Given this list of marker genes NECAP1, MINDY1, CTNS, RPP38, SERBP1, DNAJC13, SLC41A2, SNORD101, MARS2, NIPAL1, PSMD9, R3HDM1, GCNT3, TTI1, LETM1, KCTD9, ZCCHC8, TECR, RPS6, LIMA1, MOCS3, MYO1D, AHCYL2, ZNF292, OSGEPL1, RHOBTB3, SEPTIN7, SMIM14-DT, HOXA7 (NCBI Gene Id 3204), SDHD, LAMP1, EXD2, MTERF4, RGS5, NDUFB6, ZNF846, MED8, CLNS1A, SAE1, SERGEF, OXCT1, AP2S1, N6AMT1, ZC3H12D, MTRF1L, PHTF2, UQCRB, TSG101, SRRM2, TMEM260, CEP44, ZNF74, MRNIP, METTL3, RPUSD2, NDE1, RNU7-1, MTUS1-DT, PRKAG1, GDAP1, PRP4K, SHROOM3, ALOXE3, BNIP2, HOXA-AS3, LARP6, KIF20A, HMBS, SIAH1, RPUSD3, AGR2, LYSMD3, RBKS, BTNL8, JADE2, DMXL2 (Dmx like 2), PELO-AS1, SBNO1-AS1, ZNF213, EXTL3, MYLK-AS1, SMG7, ZNF436, CLDN12, ATF7IP (activating transcription factor 7 interacting protein), SH3BP5L, TRMT6, SURF6 (surfeit 6), ILF2, PPARD, MIR194-2HG, NDUFB9 (NADH:ubiquinone oxidoreductase subunit B9), DNAJC21, EIF5, NUDT12, NCOA3, SEMA4F, ABCF2, USPL1, SLAIN2, ZNF460, INTS2, EFCAB14, AKT2, GPR146, ERCC2, ZNF225-AS1 (ZNF225 and ZNF224 antisense RNA 1), LTO1 (ABCE maturation factor), RSRC2, EXD1, CFAP96, ANP32E, KAT5, ZNF426, RPAP3, SLC36A1, VARS2, AQR, SNHG20, GOT1, ZFP91-CNTF, TYW1B, MIR320A, MTERF1, ALDH4A1, VRK3, MRRF, EPC1-AS2, ZNF407, SRSF4, TM2D3, CAMKMT, TARDBP, RRH, RTCA, RPL34-DT, WBP11, H3C10, DMAC2, PIGL, INTS12, DNAJB1, IGF2BP3, ACTR1A, NSA2, RAB30-DT, TPBG, HRG-AS1, FAM120AOS, EMG1, GPATCH2, PIDD1, MBD4, ELP2, C19orf53 (NCBI Gene Id 28974), TIMM9, SHPK, PWWP2A, NDUFC2-KCTD14, MGST3, EPM2AIP1, SART3, MIR3646, RLIM, LINC02777, BRD2, GPR19, DPAGT1, DDX10, SYF2, UXS1, FKBP2, SMARCAD1-DT, VPS13B-DT, SETD5, SUMF2, RNU2-2P, MIR3678 (microRNA 3678), TFG, SPATS2L, TMEM109-DT, USF3, TMEM11-DT, ATP13A1, HOXC-AS2 (NCBI Gene Id 100874364), LSM6, REXO5, MLH1, HSPE1, KATNBL1, TTC32-DT, ITFG2-AS1, ERCC6L2, HADHB, OSR2, GAB1, IFNLR1, COPZ1 (COPI coat complex subunit zeta 1), LINC02038, IWS1, RNF111, CTDSPL2, CD164, ZNF628, RPL34, LINC00963, FGFBP3, BCKDHB, PPIA, LIN37, XPR1, H4C3, CC2D2B, CDK2AP2, ARRDC3, SLC39A8 (solute carrier family 39 member 8), CCNI, VPS13B, OXA1L-DT, SLC39A11, EBLN3P, TRIM23, RAVER1, ZNF407-AS1, RN7SK, ZNF426-DT, SLC4A1AP, ZC3H11A, RAB3D, PPP4R1-AS1, STXBP3, SLCO3A1, AP3S1, WASHC2C, MAP4K3, HERPUD1, STK25, FAM21EP, NKAPD1, CFAP298-TCP10L, PIM1, ERBB2, XRCC1, MGME1 (mitochondrial genome maintenance exonuclease 1), RBBP4, THAP2, EDN1, STAG1, ATG101, RBM48, MAP3K4, ATP11B, EDEM2, EFHD1, ITGA7 (NCBI Gene Id 81988), ERCC5, GNL1, EMP1, RPGRIP1L, TRAF3IP2, UTP23, CLASP1-AS1, RABIF, RNF126, LINC01852, RNU6-563P, VPS8, ZNF815P, CASP2 (NCBI Gene Id 835), JPT1, NDUFC2, WBP4, KIAA0586, ARHGAP5, GTF3C2, RBM39, IQCD, ACADM, C1orf21, GABARAP, CKAP2, PRPF31, USP34 (ubiquitin specific peptidase 34), MFSD1, EPRS1, RSL1D1, NCOR2, CHCHD2P6, ZNF213-AS1, GBA1LP, CCDC137, SNX24, RNU6-112P, SGO1-AS1 (NCBI Gene Id 100874028), EIF3H (NCBI Gene Id 8667), MEPCE, MIR4512, TMEM222, SREK1, UMPS, LSG1, SLCO5A1, CPSF2, ERAP2, ZNF830, RPRD1B, SMARCAD1, APBB2, DCDC1, FAM53C, VTRNA1-1, SPRY4 (sprouty RTK signaling antagonist 4), CRYZ (crystallin zeta), TIMELESS, AUTS2, BTBD3, SLC20A1, TOX4, TAF12-DT (TAF12 divergent transcript), DDB1, DNAJC24, RSL1D1-DT, FAM156A, ZNF473, MAP7, PPP2CA-DT, PRR11, ZBTB7C, LAPTM4A-DT, CAAP1, RPL27A, CDC45, BOD1, MORF4L2-AS1, RRP12, SLC22A5 (solute carrier family 22 member 5), ITPRID2, PRR15, IDH3B, ERI2, VPS50, RPL21, UFC1, G6PC3, PRPF39-DT, ZNF3, SOBP, COMMD10, GALNT16-AS1, DNAJC18, TARS1-DT, KIAA0319, WWP2, CBX5, DPP9, RETREG2, FBXL19, POGLUT1, RNASEK, CNIH1, TTC14-DT, THBS3-AS1, HDAC8, GLRX, ITM2B, RGS17P1, MYOF, ODR4, SNORA7A (NCBI Gene Id 619563), SEC14L1, NSUN2, SYTL2, HOXA10, ZNF394, USP28, NUP107-DT, SRD5A1, MTPAP, IFTAP, MEIS1, EPCAM-DT, RBM4, STK11IP, NPTN, UBE2Q1, RPS23, CCDC12, RPS27, C21orf91, NDFIP1, RNU6-2, ZNF770, KLHDC10, PSMC3IP, HOXA3, NARF, RNY3, TPCN1, ZNF687 (zinc finger protein 687), SSR3, CHAC1 (NCBI Gene Id 79094), SEMA3C, ILF3, AGL, LRRC66, SCP2, PIK3R1, QRSL1 (NCBI Gene Id 80136), PPP6R3, H4C12, SPC25, MCFD2, WARS1, EID2B, MARF1, PIPOX, ENC1, SNAPC5, TMEM259, RPS29P16, NFE2L1-DT, SLC38A7, HSPD1 (heat shock protein family D (Hsp60) member 1), SP8, MSL2, IDH3B-DT (IDH3B divergent transcript), PDSS1, RPP14, LRRC31, TEN1, RAB18, SUB1, SEC11C, FMNL3, WDR77, MRPL46, RPS27L, SMG7-AS1, SKP1, SHC4, FERMT1, BRD8, WASHC2A, MVB12A, UBLCP1 (NCBI Gene Id 134510), GARS1-DT, DDX60L, ENSG00000236098, C7orf50, TTI2, PHLPP2, DGUOK, TTC14, PPP2R1B, PSMG3 (proteasome assembly chaperone 3), CDK13, ERCC1, GLO1 (glyoxalase I), WDSUB1, RAD51-AS1, ZDHHC14, ANKRD13C-DT, C11orf58, CNOT6, SRP54, CLN3, ZNF181, ACOX1, NCLN, ITSN1, GGT7, ANG, CRYBG1 (crystallin beta-gamma domain containing 1), ERV3-1, PARK7 (NCBI Gene Id 113880), NHLRC3, EMC9, CCAR2, TNKS, TMEM232, RAB5IF, CEBPZ, EFCAB6, NDUFA6-DT, OXLD1, TCERG1, DNAJC8, PDK2, FAM21FP, RTN3, PUS10, OGDH, TMEM138, DYNLRB1, CLPB, MATCAP2, BCAS2, PPFIA3, PTPRO, ACHE, NEK7, ZSCAN2, SLC7A11, MALAT1, ATP10B, MICOS10-NBL1, SNRNP27, SMIM14, PREPL, MIX23, AP2M1, GTF2A2, RALA, MRPS35-DT, IPO4, NDUFAF7, PLOD3, RABGAP1L, TMEM229B, ATP5PO, TARBP1, HMGB3P22, GLTC1, NWD1, RBBP8, ZNF77, HOXB6, LINC01411 (NCBI Gene Id 101928176), RAD9A, ARHGAP27, PPM1D, LYPLAL1, HACD2, SLC11A2, PCYT1A, PRPF19-DT, SNRPA1, INO80B, SELENOW, DOLK, SZT2, RHEBL1, PRRC2C, OMA1, TTC19, MEF2C, WASF2, CLCN7, ITPR1-DT, THUMPD3, KNTC1, SMIM10L1, PHACTR4, ICA1-AS1, GAS5, MMADHC, FHDC1 (FH2 domain containing 1), ILF3-DT, MPC1, H4C4, DCTN6-DT, SSR2, ZFP36L2, PTPRH, SCAMP2, NPM1, TAF12, AAGAB, EFCAB6-DT, UBE4B (ubiquitination factor E4B), ZFC3H1, TBL3, CKAP2-DT, ADNP, PRLR, TRAF3IP2-AS1, ANXA4, AAK1, SNX1, RAD51AP1, NAGLU, EBNA1BP2, ZNF767P, MIR4521, ZNF12, ZNF117, POLR1G, SLC25A12 (NCBI Gene Id 8604), COQ8B, ETFA, RPS19, ENSG00000257184, NDUFS7, RPL41, KDM4C, MUTYH, PAK1IP1, NDC80, THRAP3, SRSF7, RBM27, RBCK1, TRA2A (transformer 2 alpha homolog), PSMC2, STAT6, ZFP37, EXPH5, SMPD3, PRDX3, RAB11FIP3 (RAB11 family interacting protein 3), RPL30, ATAD2B, FAM162A, CCZ1P1, ZBED5, C6orf52, TBCB, TMEM234 (NCBI Gene Id 56152), NDUFA6, ING1, TIMM8B, VPS4B, RN7SL3, FUZ, HERC4, BCO1, SBDSP1, GALNT5, ENSG00000267882, NUP107, PRKCSH, ERCC6L2-AS1, BANF1, MAEA, JKAMP, ACTR3B, DPM1, STAU1, GTPBP6, ITFG2, NFE2L3, PROSER1, FCHO2, HSD17B2, OPA1, HNRNPC, CHD8, IFT70B, HOMER1, RNF32-DT, RPPH1, PSMB7, TBC1D15, HMGN1 (NCBI Gene Id 3150), MICOS10, HERC6, MRPL24, UNK, IER5L-AS1, ZSCAN16, HNRNPA2B1, TMEM109, H3C1, TBC1D10A, RPL7L1, CNPPD1, CFAP69, PTGS2, SPNS1, KCTD16, HECTD1, LINC02068, HNRNPA1, MIRLET7IHG (NCBI Gene Id 120766144), TRPM7, UNC45A, SPICE1, TOMM7, CCDC163, TMEM205, MIIP, ERH, REV3L, ARPIN, KIZ, CD320, MRPL48 (NCBI Gene Id 51642), VASH2, SERP1, TPR, PIK3CA, CEBPZOS, MYBBP1A, WDR5B, FARSB, THADA, MEF2C-AS2, PGAP3, PEF1, INO80E (NCBI Gene Id 283899), ESRP2, BMI1, ASNSD1, RMI1, TBCCD1, SLC20A1-DT, SYMPK (symplekin scaffold protein), PCAT7, RNF10, GRPEL1, MIR7111, B4GALNT1, EPS8, ROCK2, POLR2K, MDM4, HIRIP3, C4orf19, SUPT6H, STARD4, G3BP1, ZFP91, OXA1L, ZNF25, PALS1, PRKCI, GBA1, FXR1, TMEM266, SUN1, MYG1, SH3RF2, FIRRM, UFSP2, HCG14, MCCC2, CRTC3-AS1, DNLZ, LINC-PINT, KITLG, HIBADH, NR6A1, CDON, ERCC8, RPAP3-DT, MCU, SLC18B1, MORF4L2, RACK1P1, PHF12, ZC3HAV1, TRMT10C, RPL24, SPR, RRAGC-DT, ZMAT2, PITX2, DMTF1, RRS1, RNASEK-C17orf49, ZNHIT1, EML6, ABHD14B, MOSPD3, MIR1915HG, C19orf44, KIF22 (kinesin family member 22), TSHZ1, RNU2-17P, BMS1 (BMS1 ribosome biogenesis factor), CACYBP, FAM174A, HOXB3, BRCA2, MOGAT3, ZBTB5, SPRED2, FOXA3, ISOC2, EIF2AK2, LAPTM4A, PABPN1, WDR62, WDR24, KBTBD6-DT, CBY1 (NCBI Gene Id 25776), DHX35, RBM7, SLCO5A1-AS1, ATP7B, CSNK1A1, IFRD2, ODAD3, RMDN1 (regulator of microtubule dynamics 1), IKBIP, EFCAB11, AXDND1, CIAO2A, TMC1, PPP4R3B, ACP6, UBALD2, POM121, MOCS2, H2BC5, LARS1, POLR2I, CCDC18-AS1, SERPINI1, NOL6, MOB4, TMEM183A, LIN54, RAB7A, ITGB6, HTD2, ASB8, GSPT1, PDCD2L, RANGAP1, NSMCE3, BPNT2, NUDCD1, NMT1, H2AJ, NUMA1, TNKS1BP1, NEK10, NARF-AS2, FKTN, CFAP57, SETDB2, CAP1, SLC6A6, PDCD10, TRAPPC6B, FRAT1, DEPDC4, XPOT, BCS1L, NCBP1, GDPGP1, HSPA5, UGT1A6, SORBS1, ARMH3, EIF2B1, COMMD9, PIGBOS1, PKIB, PIGS, CWC22, DSG1-AS1 (DSG1 antisense RNA 1), SUGP2 (SURP and G-patch domain containing 2), ENSG00000272008, LINC01126, CNNM2, GALNS, RAD17, ITPR1 (NCBI Gene Id 619543), GABARAPL1, ENSG00000232995, RPLP2, SNHG4, LYRM1, UXT-AS1, ZAR1L, C12orf60, HIGD2A, EID1, IFT46, PTPA, TOE1, CCDC150, TMEM39A, SESN1, DMAC2L, YIPF3, SULT1D1P, ZNF142, RIGI, P4HA1, TEN1-CDK3, YWHAZ, LIMD1-AS1, CAB39L, MAGOH, DCAKD, SLC39A9, TFDP2, TFAM, MTCH1, RAB2B, TNKS2, BRCA1, DENND2D, TMEM219, SREBF2-AS1, CSNK2A1, UXT, BTBD8, FBXW11, BTRC, RAB27A, SPINK5, THRB-AS1, COQ10B, CMC1, NBN, LINC00923, RACGAP1, ZBED5-AS1, TTC17, H2BC6, EHHADH, CNTRL, BAZ2B, CRAT, AP5Z1, DNMT1, POLR1C (RNA polymerase I and III subunit C), FNDC3A, LIN52, ZNF24, ORMDL3, YJU2B, MRPS18A, ARSK, B3GAT3, C11orf71 (NCBI Gene Id 54494), CLNK, ARMC6, ZBED6, INO80D (INO80 complex subunit D), LINC00649, EP300, MLLT3, HNRNPK, ANKRD17, SNX5, CUL5, KARS1, GABPA (GA binding protein transcription factor subunit alpha), ARRDC3-AS1, TDP1, GARS1, SGO1, HSD11B1L, CCT6B, PDXDC1, BCL6, NFE2L1, HOXA-AS2, PRR3, RNU6-502P, ZNF225, RPIA, GPR160, FAM227A, FAM200A, RACK1, SKAP2, NDUFB1, CANX, NOD1, DYNC2H1, DOHH, GRPEL2 (NCBI Gene Id 134266), MIR1915, RPS17, IFT122, MFSD8, SDF2, TRAPPC2L (NCBI Gene Id 51693), RAB28, LINC03015, TNRC18, SIRT4, BRD10, FOS, CLRN3, ALKBH8, NUP188, VPS33A, UBE2L6, R3HDM2-DT, AKAP9, GEMIN2, ACAD10, ORC5, FER, ARPIN-AP3S2, CCDC127, GDF9, SOX6, APC, CCNL1, ISL2, MCM8, CACNB2, HES1, SRGAP3, ELP3, MED4, LPXN, LMO7, SKIC3, PPP1R12B, CEP85, BLOC1S1, C10orf143, DCUN1D3, LUC7L2, MIA3, SPIN1, CYP4F12, RAB29, EIF3A, LSM2, LINC00471, RNU6-841P, SYAP1, PSME2P3, EZH1, SULT6B1, TMBIM6, NAA38, CDC27, HPS1, PJA2 (praja ring finger ubiquitin ligase 2), P4HB, PCCA, WNK1, RSBN1L, ALDH6A1, XPO1, KBTBD6, PPP1R13L, CCDC125, SUCLG1, CCDC159, LINC02168, DCTN4, ATG12, TXNDC9, SHLD3 (NCBI Gene Id 112441434), RIMKLB, KLHL12, RTN4IP1, SERF2, LSM8, PANK4, SLC39A6, HDAC5, MMUT, MCC, NEMF (NCBI Gene Id 9147), ARL5A, FAM13A, ISLR2, SELENOOLP, PTPRE, WDR25, TACC2, MAP3K5, INO80 (NCBI Gene Id 84156), SLC25A46, MIS12, ATP6AP1L, FAN1, MRPS15, SRRM2-AS1, ORAI1, NHSL1, WDR5B-DT, HNRNPH3, ZSWIM7, QTRT1, RBIS (ribosomal biogenesis factor), SLCO2B1, PEF1-AS1, RND3, NCAPG2, TRIM69, PIGB, FBXO33, HNRNPA3, MIA2, SPATA17, AASDH, PHB2, MARCHF8, LINC00511, TMSB10, ATXN2L, HSPA9, CEP57L1, ISOC1, SOS1, DAB1, NDUFS8, DERL2, PAPSS1, CDS2, C12orf57, SRP19, CREBRF, ZNF684, BTN3A3, REG4, RBM47, WDR74 (WD repeat domain 74), DPYSL2, RAB30, LINC03014, AGAP2-AS1, ATR, MNAT1, CCNJL, NDUFAF6, CALCOCO1, PVR, ARHGEF37, DLEU2, TRPC4AP, NUF2 (NUF2 component of NDC80 kinetochore complex), MRPS22, SMARCAL1, DDX46, CENPQ, INO80B-WBP1, BCL2L14, TARS1, MALINC1 (mitosis associated long intergenic non-coding RNA 1), PRR7, EIF1, MRPS11, HSP90AB1 (heat shock protein 90 alpha family class B member 1), CUL2, MRPL43, CHD2, BTBD1, ZW10, TKFC, USP3-AS1, IMMP1LP1, SDHC, NCK2, RPL26, TWNK, BAG6, ATAD2, RPL32, NFATC2IP, SNX10, DMTF1-AS1, ZNF436-AS1, KBTBD2, CA13, TMCO4, SNCAIP, PISD, MCOLN1, TBL1XR1, NFXL1 (NCBI Gene Id 246220), CALM2, TFPT, PFDN4, RFX3, TTC32, RPL30P11, MMACHC, RALBP1, SCARNA16, TEC (NCBI Gene Id 7006), HMGB1, TMCO6, SNORD95, RNF216, NRBF2, TATDN1, SUPT7L, H3-3B, EHD4, SLC52A3, H4C16, LAMA3, TERF2IP, CBLB, OSGEPL1-AS1, RBM25, CCNB1, CAST, SYVN1, ANKRD13C, RPS12, COA6, TMBIM1, MEF2A, CEP63, ERCC4, MIR4757, SOX2-OT, MATR3, RPL36, ABCB6, SPRYD4, FTO (NCBI Gene Id 79068), TMEM11, PPP2CA, CFAP298, TK2, USP22, NUB1, EHF, ST3GAL2, ALDH7A1, ZRANB3, SRSF5, UQCR11, EIF3K, NFKBIZ, GET4, AGPS, ADCY3, EEF1AKMT1, CHP1, C2orf88, NR2F2, VAPA, BCL2L13, H2BC13, SRPK1, SRP54-AS1 (NCBI Gene Id 102723366), MAPKAP1, PIH1D2, SMAD5, USP16, PPP1R12A, ENSG00000275740, FAM114A2, MGST2, NEDD9, CREBZF, ZNF446, PLAC8, DHX35-DT, PRR7-AS1, ATP5PF, OTUD4, RAD51, LINC02615, UFD1, MTOR, ZFAND1, MAP4K1, RRS1-DT, SRSF10, COX6B1, ZNF343, ACSS2, DCTN2, PRPF19, TBC1D7, YJU2, TGIF1, CDCA2, GRB2, BLM, POLR3D, GFM1, AHCTF1, EIF3I, HOTTIP, RXFP4, ENSG00000275765, CALR3, TRIM37, CYB5D1, FKBP3, UQCRQ, SUPT4H1, LINC02971 (NCBI Gene Id 124904558), ZNF774, TRIQK, HSPA8, MOCS2-DT, NOSIP, PYROXD1, SNRPA1-DT, GFM2, ARL2BP, MAP3K13, XPNPEP1, PSMD6, RPS29 (ribosomal protein S29), CHRNB1 (cholinergic receptor nicotinic beta 1 subunit), TTC7A, PCBP2, MORN4, LINC02366, THBS4, FAM135A, TNK2, S100A14, NCBP2AS2, C17orf100, PEX13, RBM34, RPS27A, NUP35 (NCBI Gene Id 129401), PPP4R1, NCBP2, TDO2, EIF5B, OSBPL8, C4BPB, SEPTIN7-DT, CYB561A3, SNORD13, SACM1L, METTL18, LINC02100, MICOS13, RNASE4 (ribonuclease A family member 4), TNRC6B, TFB1M (transcription factor B1, mitochondrial), ZCWPW1, MKRN2, C11orf52, CTDSPL2-DT, FAM174A-DT, GOT1-DT, MARCHF7, PPIAP31, COQ2 (coenzyme Q2, polyprenyltransferase), EIF3E, CSDE1, RNU1-117P, FGD6, GSTCD, ERGIC2, WBP2, PLA2G2A, GSTA4, PRR13P5 (NCBI Gene Id 651143), TRAPPC13, ANXA2R-AS1, GTF2H4, here is a description of the gene set: from publication Yevshin I, Sharipov R, Kolmykov S, Kondrakhin Y, Kolpakov F (PMID 30445619) Human Gene Set: NKX2_2_TARGET_GENES Genes containing one or more binding sites for (NKX2-2) in their promoter regions (TSS -1000,+100 bp) as identified by GTRD version 20.06 ChIP-seq harmonization. studied in species Homo sapiens